Given this list of marker genes CATSPER2, DAZ1, CFAP300, WT1, SOX9, ODAD3 (NCBI Gene Id 115948), MECP2, CCDC39, MAD2L2, DNAH17, BUD23, DNAAF5, CFAP61, FGFR1, ARMC12, RPGR, GBA1, ANAPC1, IFT74, KCNU1, FANCI, MEN1, NR0B1, TXNRD2, IFT140, FANCG, SYCP2, TEX11, LHB, BCL10, SPRY4, LRRC23, NCF1, FANCB, CDC14A, WWOX, XRCC2, DNAI2, DNAI1, PMFBP1, BAZ1B, NEK10 (NCBI Gene Id 375328), HSFY1, FSHB, ODAD1, MCIDAS, TSPY1, VPS37D, CEP19, TAF4B, RPS4Y2, CHD7, GTF2IRD1, CDH23, CCDC34, MRAP, PNLDC1, AIP, TMEM270, EIF2S3, GTF2IRD2, DAZ3, LHCGR, DNAH11 (NCBI Gene Id 8719), DNAH5, CFAP69, FANCL, USP9Y, SYCE1, DAZ2 (NCBI Gene Id 57055), ALG5, CFAP47, DHX37, RNF212, CFAP45, POR, WNT4, AK7 (adenylate kinase 7), SEMA3A, ARL2BP, OCRL, DNAH8, RSPH1, HJV, IFT172, NR3C1, KISS1R, TAC3, MCM8, LRRC56, RAD51, SCP2, ADGRG2, C14orf39, RFC2, ANTXR1, DAZ4 (NCBI Gene Id 57135), TEX15, DNAAF1, CFAP91, DUSP6, DNAJB11, TERB2, RFWD3, SLC26A8, CT55, TTC29, CFAP410, ALMS1, RSPH3, SPAG1, PRKAR1A, DNAH9, BICC1, FBXO43, WFS1, DNAL1, DNALI1, ERCC8, FANCM, TACR3, BRIP1, BLM, PDE11A, USP26, CFAP70, ALG9, STEAP3, DNAJB13, PANX1, CCDC40, KLHL10, TEX14, STK36, DNAAF2, BRCC3, WDR11, LIMK1, ELN, CFTR, MEIOB, TEKT3, CCDC146, CATSPER1, DRC1, CEP112, DNAH2, MSH4, SLX4, ANK1, HFE, SYCP3, FANCF, DNAAF11, FANCA, CDY2A, CNBP, STAG3, SPACA1, AKAP3, KISS1, PALB2, CLIP2, MC2R, FANCC, ZMYND15 (NCBI Gene Id 84225), HSD3B2, XKRY, SOHLH1, MAP3K1, CCIN, STRC, PROKR2, FSIP2, STK11, PKD1, SLC29A3, BRDT, ODAD2, GTF2I, NHLH2, ERCC1, STK33, GNRH1, NSMF, CFAP58, STX1A, ZMYND10 (NCBI Gene Id 51364), CYP17A1, CTNS, FGF8, FANCE, PROK2, ANOS1, BPY2, NNT, BRCA2, STAR, OFD1, HNF1B, UBE2T, SPAG17, M1AP, VCY, NME8, WDR19, ZSWIM7, EIF4H, POLD1, POC1A, ARMC2, CDY1, PDHA2 (pyruvate dehydrogenase E1 subunit alpha 2), KDM5D, METTL27, DNHD1, HS6ST1, TDRD9, WEE2 (WEE2 oocyte meiosis inhibiting kinase), TERB1, CISD2 (NCBI Gene Id 56831), CCNO, CFAP221, GCNA, RAD51C, ABCD1, CFAP74, KASH5, CFAP43, DZIP1, AIRE, CYLC1, BRWD1, ERCC4 (NCBI Gene Id 7509), ODAD4, ZFPM2, NANOS1, TUBB8, DNAAF3, SPATA22, RSPH4A, DNAH1, SUN5, HYDIN, CFAP298, BRCA1, KIT, CFAP251, PATL2, PKD2, SRY, SPINK2, FGF17, SEPTIN12, AR, DNAH7, GATA4, TBL2, SHOC1, SOX3, DNAAF4, DNAAF6 (dynein axonemal assembly factor 6), VAMP7, DDX3Y, FOXJ1, NME5, FANCD2, CFAP65, BMP2, RSPH9, TTC21A, RBMY1A1, ERCC6, SPEF2, GAS2L2, GANAB, DNAJC30, NR5A1, MOV10L1, ATM, DHH, GNRHR, CLDN2, SSX1, DNAH10, TTC12, FGFR3, MSH5, CATIP, GBA2, FKBP6, POLA1, RPL10L, here is a description of the gene set: species: Homo sapiens Functional abnormality of male internal genitalia Human Gene Set: HP_FUNCTIONAL_ABNORMALITY_OF_MALE_INTERNAL_GENITALIA